Given this list of marker genes Atp1b2, Tescl, Wnk3, Drd4, Arf1, Tesc, Fxyd1, Atp1b3, Chp1, Plcb1, Wnk2, Atp1b1, Fxyd3, Fxyd5, Prss8, Fxyd7, Dmd, Fxyd4, Scn1b, Cnksr3, Slc9a1, Fxyd6, Fgf13, Fxyd2, Ank3, Nos1, here is a description of the gene set: Any process that activates or increases the frequency, rate or extent of sodium ion transmembrane transport. Mouse Gene Set: GOBP_POSITIVE_REGULATION_OF_SODIUM_ION_TRANSMEMBRANE_TRANSPORT studied in species Mus musculus